The following is a description of a gene set: Mouse Gene Set: CUI_NK_CELL_NEUROPOIETIN_RESPONSE_UP from publication Cui A, Huang T, Li S, Ma A, Pérez JL, Sander C, Keskin DB, Wu CJ, Fraenkel E, Hacohen N (PMID 38057668) Cytokines mediate cell-cell communication in the immune system and represent important therapeutic targets. A myriad of studies have highlighted their central role in immune function, yet we lack a global view of the cellular responses of each immune cell type to each cytokine. To address this gap, the authors created the Immune Dictionary, a compendium of single-cell transcriptomic profiles of more than 17 immune cell types in response to each of 86 cytokines (>1,400 cytokine-cell type combinations) in mouse lymph nodes in vivo. A cytokine-centric view of the dictionary revealed that most cytokines induce highly cell-type-specific responses. For example, the inflammatory cytokine interleukin-1β induces distinct gene programmes in almost every cell type. A cell-type-centric view of the dictionary identified more than 66 cytokine-driven cellular polarization states across immune cell types, including previously uncharacterized states such as an interleukin-18-induced polyfunctional natural killer cell state. studied in species Mus musculus Genes positively differentially expressed in cell type: NK cell upon treatment with cytokine: NP in mouse lymph nodes in vivo., and this is the list of marker genes: Pigyl, Tagln2, Sumo2, Rbmxl1, Chmp2b, Pitrm1, Tubb4b, Unc119, Abcf2, Dmap1, Gzmb, Trpv2, Lyz1